Given this list of marker genes Padi2, Abr, Hc, Cd69, Grem1, Slit2, Ccn3, Cd200r1, Cyp19a1, Gcsam, Ifnb1, Klrk1, Akt1, Nbl1, Apod, Wasl, Adtrp (NCBI Gene Id 77346), Il27ra, Cnn2, Lrch1, Ccl12, Stap1, Bcr, Cd200, Mmp28, Mif, Ripor2, Slamf8, Mia3, Emilin1, Plcb1, Dusp1, here is a description of the gene set: Mouse Gene Set: GOBP_NEGATIVE_REGULATION_OF_MONONUCLEAR_CELL_MIGRATION studied in species Mus musculus Any process that decreases the rate, frequency or extent of mononuclear cell migration. Mononuclear cell migration is the movement of a mononuclear cell within or between different tissues and organs of the body.